Given this list of marker genes Aldh2, Cd24a, Ppm1m, Cyrib, Plac8, Hdac1, Myo1f, Cmpk1, Vapa, Oaz1, Cdk11b, Mettl9, Abhd5, Eif3a (eukaryotic translation initiation factor 3, subunit A), Rps29, Ddx3x, Ifitm6, Sfpq, Serpinb1a, Smdt1, Plp2, Med8, Nedd8, Rab28, Rdx, Rpl29, Cd177, Itgb2l, Rps28, Lmo4, Atrx, Scp2, Sarnp, Tbca (NCBI Gene Id 21371), Son, Ndufa6, Tmem167, Cebpe, Hsp90b1, Cdk1, Chil3, Lims1, Ltb4r1, Cox5a, Trir, Tbrg1, Hnrnpa2b1, Ndufc1, Polr1d, Pfdn5, Hint1, Tubb5, Hmgn2, Brk1, Cct4, Psmc3, Rnaseh2c, Lyn, Cd63, Sft2d1, Syne1, Rpn1, Sri, Alas1, Sqor, Rps6ka1, Mrgpra2b, Ywhab, Anxa5, Arhgdib (NCBI Gene Id 11857), Psmb5, Ralbp1, Tuba4a, Ak2, Ywhae, Gdi2, Cybb, Prtn3, Snx6, Ppp1r12a, Anapc13 (NCBI Gene Id 69010), Emp3, Mpst, Ctbp1, Ndufb7, Lrrfip1, Tram1, Pdia3, Birc5, Usp39, H2az1 (NCBI Gene Id 51788), Tmpo, Adpgk, Atp5me, Asnsd1, Chmp2a, Kif5b, Triobp, Rbm25, Ggnbp2, Atp5pf, Rock1, Dbi, Cope, Tpr, Rab3d, Itgb2 (integrin beta 2), Rrm2, Top1, Clta, Cox6a1, Lsm5, Ngp, Dync1i2, Lta4h, Rgs19, Atp5f1a, Eef2, Cep19, Rnf10, Ltf, Tomm6, Ndufb2, Hsd17b10, Sdcbp, Rpl22l1, Cenpa, Gyg1, Tbc1d8, Ndufb3, Arf1, Ncf4, Tle5, Lasp1, Mki67, Myl12b, Card19, Anxa3, Pgp, Tpi1, Mrps21, Pitpna, Pak2, Ndufa1, Eif3f (NCBI Gene Id 66085), Ap3s1, Slfnlnc, Rab14, Mapk13, Cuedc2, Add3, Rflnb, Hnrnpab, Ppp1cb, Cebpd, Ckap4, Ndufb8, Tsc22d4, Sumo3, Wfdc21, Rps8, Hnrnpk, Hipk1, Rpl31-ps12, Atp6v0d1, Evi2b, Plin3, Cotl1, Etfb, Myl12a, Tkt, Tomm7, Eif1b, Gtf2a2, Cyc1, Cyb5r4, Psma6, Rgs18, Arid4a, Sub1, Nucks1, Tmem234, Atp5f1e, Top2a, Srp9, Ostc, Serbp1, Atp5mk, Lrrc58, Ywhaz, Hnrnpa3, Smim14, Ptpre, Aldh3b1, Glrx, Camp, Tecr, Gabarap, Hhex, Tln1, Atp5if1, Ncoa4, Cops9, Rbm3, Rasgrp2, Atp5f1b, Sec61g, Mpc2, Dstn, Baz1a, Vcp, Crispld2, Atp6v1e1 (NCBI Gene Id 76771), AA467197, Macir (macrophage immunometabolism regulator), Rpl36, Ly6c2, Ets1, Rpl38, Lcn2, Arhgap30, Vamp8, Cyfip2, Krcc1, Srrm2, here is a description of the gene set: species: Mus musculus from publication Tabula Muris Consortium (PMID 32669714) Mouse Gene Set: TABULA_MURIS_SENIS_SPLEEN_GRANULOCYTE_AGEING